Given this list of marker genes SPATA25, ADIPOR1, SLC26A4, GPR146, AHSP, SLC25A5, WDR86, ACP4, GULP1, TENT5C, RAX2, PFKFB2, FTCD, MKRN1, ZNF423, MYH7B, HS3ST5, FBLN2, STRADB, EEF1B2, SLC4A3, LRRC72, RPS5, HBB, TRAK1, IMPG2, TMEM177, RUBCNL, FBXO7, ARL14, BRS3, DPY19L1P1, UBE2G2, ANK1, ELFN2, SPTB, BPGM, HBD (NCBI Gene Id 3045), GLRX5 (NCBI Gene Id 51218), RPLP0, GRIN2C, NPRL3, KANK2, ZDHHC23, ADAMTSL1, PSME4, MOB3B, GUCD1, LRRC4B, DCAF12, CAMK1D, PPM1A, ESPN, ALAS2, HBM, RPL7A, RAP1GAP, TMEM247, HBBP1, CNTN2, OR2W3, RUNDC3A, NOX1, PALD1, AADAC, GABARAPL2, TMOD1 (NCBI Gene Id 7111), MBNL3, GYPE, MGAT4D, ABCC13, SLC25A37, PLEKHS1, ADGRG4, LINC02153, NSUN3, MATN2, SIRT4, TESC, ABCG2, MPPED2, SESN3, DUSP21, CT55, IL1R2, BEND4, GSPT1, C1GALT1C1L, LINC02239, HAGH, GNG3, SNCA, MICAL2 (microtubule associated monooxygenase, calponin and LIM domain containing 2), TRPC5OS, VCF1, TCEAL2, CR1L, PLEK2, ALDH4A1, FZD8, LYZL4 (NCBI Gene Id 131375), SLC14A1, DNAJC6, RASL11A, RNF10, RAB9BP1, TMEM184A, GPR161, BNIP3L, ACSS1, CYP2W1, CYP4F12, LINC00494, LINC01116, HTRA3, PIP5K1B, PINK1, PCDHB12, RAB2B, HBZ, DDX4, DAND5, HEPACAM2, DDX6, DPYS, ANKRD60 (ankyrin repeat domain 60), CCNDBP1, GYPA, TRIM10 (NCBI Gene Id 95309), TRIM51, HBQ1, PCDHB13, CA1, KLF1, MXI1, TERF2IP (TERF2 interacting protein), PXDN, HEMGN, DEFT1P, FAM210B, SLC25A39, RPL26L1-AS1, GPC3, SLC6A8, RNF11, TCL1B, TRIM64EP, RPIA, PMEPA1, CDC34, BDNF-AS, SMIM24 (NCBI Gene Id 284422), ST13, FRMD4A, EBF1, DYNLT5, GPR135, EPB41, UBE2O, BMS1P2, TCP10L, MARCHF8, TSPAN10, PPP1R3B-DT, MRC2, GCGR, HTR7, FECH, TUNAR, MYL4, FLYWCH2, LAMA3, RNF182, SELENBP1, MAP4K3-DT, SLC16A4, EFNA1, EPB42, ZDHHC11, DLK2, BCL2L1, USP12, PITHD1, NCKAP5, SLC4A1, TRO, MAGEB4, LRRC56, FRZB, TNS1, OR2L1P, GGTLC2, FADS3, ZNF461, here is a description of the gene set: Genes up-regulated in comparison of peripheral blood mononuclear cells (PBMC) from infancts with acute RSV infection versus PBMCs from infants with acute influenza infection. from publication Ioannidis I, McNally B, Willette M, Peeples ME, Chaussabel D, Durbin JE, Ramilo O, Mejias A, Flaño E (PMID 22398282) To study the transcriptional profile of patients with acute RSV or Influenza infection,children of median age 2.4 months (range 1.5-8.6) hospitalized with acute RSV and influenza virus infection were offered study enrollment after microbiologic confirmation of the diagnosis. Blood samples were collected from them within 42-72 hours of hospitalization. We excluded children with suspected or proven polymicrobial infections, with underlying chronic medical conditions (i.e congenital heart disease, renal insufficiency), with immunodeficiency, or those who received systemic steroids or other immunomodulatory therapies. The RSV cohort consisted of 51 patients with median age of 2 months (range 1.5-3.9) and the influenza cohort had 28 patients with median age of 5.5 months (range 1.4-21). Control samples were obtained from healthy children undergoing elective surgical procedures or at outpatient clinic visits. To exclude viral co-infections we performed nasopharyngeal viral cultures of all subjects. We recruited 10 control patients for the RSV cohort with median age of 6.7 months (range 5-10), and 12 control patients for the influenza cohort with median age of18.5 months (range 10.5-26). Human Gene Set: GSE34205_RSV_VS_FLU_INF_INFANT_PBMC_UP species: Homo sapiens